The following is a description of a gene set: A structural anomaly in the fetal neck region. Terms in this subhierarchy are restricted to findings that can only be observed in the prenatal period. Other HPO terms can also be used to describe fetal phenotypes. Human Gene Set: HP_FETAL_NECK_ANOMALY Fetal neck anomaly species: Homo sapiens, and this is the list of marker genes: CBL, MUSK, VPS37D, ARSL, SMC3, PEX3 (peroxisomal biogenesis factor 3), BUB1B, CSGALNACT1, RAP1B, TMEM106B (NCBI Gene Id 54664), RRAS, COG8, GTF2IRD2, MRAS, BUB3, FKBP6, VCP (valosin containing protein), HNRNPK, PEX14, FOXF1, LRPPRC, VAC14, GRN, EBP, SPRED2, TRIP11, SOS2, HRAS, STX1A (NCBI Gene Id 6804), TRIP13, RNU4ATAC, PEX1, TBC1D24, EIF4H, CEP57, TBL2, ATN1, DHPS, DHCR7, TMEM270, SLC31A1, BAZ1B, ALG9, MAPT, PEX5, ADARB1, TAF6, PEX6, GPC6, RRAS2, GTF2IRD1, LZTR1, SLC35A2, RNU4-2, PEX13 (peroxisomal biogenesis factor 13), ATP6V1B2, FGFR3, DOCK11, PTPN11, EPHB4, SLC26A2 (NCBI Gene Id 1836), TCF4, METTL27, NRAS, BUB1, DNAJC30, RAD21, PEX19, TRAF7, LIMK1, LAMA5, ABCC6 (NCBI Gene Id 5823), CHMP2B, STAG1, PEX2, TREM2 (NCBI Gene Id 54209), PEX16, BUD23, ITPR1, BRD4, GTF2I, CLIP2, FIG4 (NCBI Gene Id 9896), NIPBL, WWOX, PIGA, RAB34 (RAB34, member RAS oncogene family), RAF1, PEX11B, SQSTM1, HDAC8, SMC1A, RFC2, EFNB1, PEX10, BMPER, KRAS, PIGN (NCBI Gene Id 23556), MYL11, LBR, ODC1, ELN, PEX26, RASA2, SOS1, ENPP1, NCF1, PSEN1, DOHH, PEX12, RIT1, TXNDC15, PSAT1